Given this list of marker genes NFKBIA, KRT35, LIMK1, GSTT1, MMP3, TNFAIP3, CSF3, VCAM1, MMP13, CD68, IL6, MADCAM1, NOTCH3, CD6, BCL2L10, GDF15, ADGRG1, CCL5, TRAF1, SELE, SELP, JUN (NCBI Gene Id 3725), CSF2, YY1, IGDCC3, here is a description of the gene set: Representative genes up-regulated in MEF cells (embryonic fibroblast) in response to TNF. Human Gene Set: WANG_TNF_TARGETS from publication Wang H, Hertlein E, Bakkar N, Sun H, Acharyya S, Wang J, Carathers M, Davuluri R, Guttridge DC (PMID 17438126) studied in species Mus musculus NF-kappaB signaling is implicated as an important regulator of skeletal muscle homeostasis, but the mechanisms by which this transcription factor contributes to muscle maturation and turnover remain unclear. To gain insight into these mechanisms, gene expression profiling was examined in C2C12 myoblasts devoid of NF-kappaB activity. Interestingly, even in proliferating myoblasts, the absence of NF-kappaB caused the pronounced induction of several myofibrillar genes, suggesting that NF-kappaB functions as a negative regulator of late-stage muscle differentiation. Although several myofibrillar promoters contain predicted NF-kappaB binding sites, functional analysis using the troponin-I2 gene as a model revealed that NF-kappaB-mediated repression does not occur through direct DNA binding. In the search for an indirect mediator, the transcriptional repressor YinYang1 (YY1) was identified. While inducers of NF-kappaB stimulated YY1 expression in multiple cell types, genetic ablation of the RelA/p65 subunit of NF-kappaB in both cultured cells and adult skeletal muscle correlated with reduced YY1 transcripts and protein. NF-kappaB regulation of YY1 occurred at the transcriptional level, mediated by direct binding of the p50/p65 heterodimer complex to the YY1 promoter. Furthermore, YY1 was found associated with multiple myofibrillar promoters in C2C12 myoblasts containing NF-kappaB activity. Based on these results, we propose that NF-kappaB regulation of YY1 and transcriptional silencing of myofibrillar genes represent a new mechanism by which NF-kappaB functions in myoblasts to modulate skeletal muscle differentiation.